The following is a description of a gene set: from publication He P, Lim K, Sun D, Pett JP, Jeng Q, Polanski K, Dong Z, Bolt L, Richardson L, Mamanova L, Dabrowska M, Wilbrey-Clark A, Madissoon E, Tuong ZK, Dann E, Suo C, Goh I, Yoshida M, Nikolić MZ, Janes SM, He X, Barker RA, Teichmann SA, Marioni JC, Meyer KB, Rawlins EL (PMID 36493756) studied in species Homo sapiens PCP4+ neuron Human Gene Set: HE_LIM_SUN_FETAL_LUNG_C7_PCP4_POS_NEURON_CELL, and this is the list of marker genes: SV2C, B3GNT4, HMGCLL1, RUNDC3B, SLC6A2, SST, PNCK, PLCB2, PLPP4, NTNG1, HRH1, SCN3B, PRUNE2, SNCG, SH3GL2, PCP4, GNAO1, CELF5, KLHL5, RGS4, ENTPD3, CPLX2, AKR1C2, ATP6V1G2, ISL1, DLGAP1, SEPTIN3, TMEM130, GATA3, CHRM3, SULT4A1, FRY, FAIM2, LY6H, SPOCK3, TRPV2, DHCR24, ACHE, TMOD1, ARHGEF28, SYBU, SLC8A1, SCN2A, ELAVL2, CNKSR2, PENK (proenkephalin), ELMO1, SLC18A2, RBFOX1, SYT4, HOXD1, PRSS3, GRIA3, NSG2